Given this list of marker genes GOPC, CFTR, RHOQ, here is a description of the gene set: Activated RHO GTPase RHOQ (TC10) regulates the trafficking of CFTR (cystic fibrosis transmembrane conductance regulator) by binding to GOPC (Golgi-associated and PDZ and coiled-coil motif-containing protein) also known as PIST, FIG or CAL. GOPC is a Golgi resident protein that binds several membrane proteins, thereby modulating their expression. In the absence of RHOQ, GOPC bound to CFTR directs CFTR for lysosomal degradation, while GTP-bound RHOQ directs GOPC:CFTR complex to the plasma membrane, thereby rescuing CFTR. studied in species Homo sapiens Reactome Pathway: RHO GTPases regulate CFTR trafficking part of: RHO GTPase Effectors